Given this list of marker genes Cfl1, Ctsd, Tmsb10, Rpl13a, Tle5, Apoe, Dcn, P2ry12, Gstm1, Gsn, Snrpc, Oaz1, here is a description of the gene set: species: Mus musculus Mouse Gene Set: TABULA_MURIS_SENIS_HEART_T_CELL_AGEING from publication Tabula Muris Consortium (PMID 32669714)